The following is a description of a gene set: Reactome Pathway: PKR-mediated signaling species: Homo sapiens Interferon-induced, double-stranded RNA-activated protein kinase PKR (EIF2AK2) mainly halts cellular protein translation by phosphorylating eIF2α, which blocks the recycling of GDP-eIF2 to GTP-eIF2 required for cap-dependent translation initiation. PKR is constitutively expressed at low level, and its expression is up-regulated by interferon alpha/beta signaling. PKR is mainly localized in the cytoplasm with a small fraction in the nucleus (Tian & Mathews 2001). <br>PKR was identified in the 1970s. Its activation is characterized by the shifting of its monomer/dimer equilibrium towards the dimer, with subsequent autophosphorylation. Possible activating factors include binding of viral dsRNA to the PKR dsRNA binding domain, as well as cellular proteins (ISG15, PACT, DCP1A) and heparin (Patel & Sen, 1998; Dougherty et al., 2014; George et al., 1996; Fasciano et al., 2005; reviewed by Zhang et al, 2021). General translation shutdown by PKR can therefore be promoted by both viral infection and the integrated response of the cell to stress stimuli. Several cellular inhibitors of PKR activation and eIF2α phosphorylation by PKR have been identified and binding of PKR to viral proteins from RNA viruses (e.g. HIV, influenza A, RSV) has also been shown to contribute to inhibition. In addition to its role in translation shutdown via eIF2α, PKR affects translation through NFAR protein phosphorylation; it can also phosphorylate RNA helicase A, CDC2, and MKK6, thus modulating RNA metabolism, G2 arrest, and p38 MAPK activation. Finally, PKR can bind to TRAF proteins, the IkappaB kinase complex, GSK-3beta, and several inflammasome components leading to NF-kappa B activation, tau phosphorylation, apoptosis, and inflammasome activation. part of: Antimicrobial mechanism of IFN-stimulated genes, and this is the list of marker genes: TUBA4B, ISG15, MAPT, SNCA, TUBB1, DHX9, NPM1, TUBB2B, TUBB4B, TRIM25, TUBA1C, TUBB4A, CDK1, CHUK, CENPS, TUBA1B, VTRNA2-1, SPHK1, FANCM, ADAR, TUBAL3, EIF2S2, DNAJC3, TUBA3C, EIF2S1, TARBP2, MAP2K6, FANCE, FANCF, HSPA2, FANCG, FANCA, FAAP100, STAT1, DUS2, PPP2CA (protein phosphatase 2 catalytic subunit alpha), IKBKB, FANCC, TUBA3D, TUBA1A, TUBB3, NS, UBE2I, TUBA8, PRKRA, TUBA4A (NCBI Gene Id 93373, tubulin alpha 4a), SUMO1, STAT3, HERC5, EIF2AK2, FANCB, MAVS, TUBB8, TP53, ILF3, tat, HSPA8, CENPX, TUBB8B, N, PPP2R1A, FANCL, ILF2, TUBB2A, IKBKG, FAAP24, FAAP20, PPP2R5A, NCK1 (NCBI Gene Id 4690), PPP2R1B, EIF2S3, PTPN2, HSPA1B, PPP2CB, TRS1, UBE2L6 (NCBI Gene Id 9246), ARIH1, HSPA1L, TUBA3E, TUBB6, HSPA1A